Given this list of marker genes LAPTM5, GRIPAP1, LCK, PDE1B, MARCKSL1, SPAG9 (sperm associated antigen 9), AMZ1, HLA-DRA, REL, ATP6V0A1, BEX3, AHR, PEA15, RCHY1, CD72, GAA, TPRA1, EGFL6, MAP2K3, CD84, RPS6KA2, ORAI1, IGF2R, ZFP36L2, CD86 (CD86 molecule), PLEK, MIR22HG, VCL, PCYT1A, DLK1, TPD52 (tumor protein D52), FNBP1, SSBP4, CCR6, ITPRID2, TOB2, FOSL2, PFKP, UBE2D1, RASA2, PLEKHF2, OXCT1, TCEAL9, EPHA8 (EPH receptor A8), VEGFB, CORO7, EMILIN2, LAT2, MYO1E, SLC9B2, SLC38A1, SPRY1, ERF, DGKD, SLC17A9, IL2RG, FABP5, IL7R, SMAD3, MIDEAS, SARS1, PMP22, SLCO4A1, NFATC1, PER1, TXNDC16, PRXL2A (NCBI Gene Id 84293), RBPJ (NCBI Gene Id 51580), GNG4, AK7, IL33, GFI1, PTGER4, CHRND, PTPN22, LONRF3, RGS2, MAST3, CD53, SPP1, TUBB2A, UAP1L1, LYL1, LBH, SH3BGRL, CHST11, RAB3GAP2, CCNG2, GATA5, MALT1, GPR183, UBP1, CBX7, IL6ST, DUSP4, STARD4, C11orf96, NRGN, OVOL2, TNFRSF13C, RASD1, DMTF1, DDIT4, RILPL2, SLC17A5, CBLC, TRIB2 (tribbles pseudokinase 2), RETREG1, LZTFL1, RHOF, EPHX1 (epoxide hydrolase 1), M6PR, WIPF1, ATP6V0D1, CR2 (NCBI Gene Id 1380), IL1R2, XCL1, OSBPL3, EGR2, RENBP, NSMF (NCBI Gene Id 349336), VPREB3, B3GNT5, ALCAM, SACS, S1PR3, HLA-DRB1, SNAI3, CXCR3, CSTB, IRS2 (NCBI Gene Id 90066), IER2, RGS1, RMND5B, BCL9, CD27, MYO1C, PDE2A, MANEA, DTX1, MYO1B, TMEM40, HIVEP3, TGFB1, KRTCAP3, IRF2BPL, TPST2 (tyrosylprotein sulfotransferase 2), XBP1, RGS16, MMD, EGR1, NCS1, NR4A2, FCMR, SEMA4D, LAT, USP2, ZSWIM4, FOSB, NAB1, SEPTIN7, TSC22D1, NR4A3, KLF10, LITAF, RGS13, CST7, CD74, CHKA, TMC6, KLHL18, SRPK2, DCAF12, CABLES1, CTSA, TIPARP, PRKCA, TUBA3C, WDR81, INPP5D, EYA3, HIC1, TUBB2B, CD28, TMEM51, LRRC8D, CYBA, DMXL1, NAB2, PLBD1, EGR3, AP1M2, ITGAV, C18orf54, BEX1, FOXN2, IDE, SH2D2A, TMEM74B, FXYD5, here is a description of the gene set: CD4 T follicular helper (Tfh) cells provide the required signals to B cells for germinal center reactions that are necessary for longlived antibody responses. However, it remains unclear whether there are CD4+ memory T cells committed to the Tfh lineage after antigen clearance. Using adoptive transfer of antigen-specific memory CD4+ subpopulations (based on CXCR5 and Ly6c expression)in the LCMV infection model, we found that there are distinct memory CD4+ T cell populations with commitment to the Tfh and Th1 lineages. Our conclusions are based on gene expression profiles, epigenetic studies and phenotypic and functional analysis. The gene expression profiles of virus-specific CD4 T cell subets at effector and memory stages is presented here. Genes up-regulated in Th1 CD4 SMARTA T cells: effector during acute infection of LCMV versus memory. from publication Hale JS, Youngblood B, Latner DR, Mohammed AU, Ye L, Akondy RS, Wu T, Iyer SS, Ahmed R (PMID 23583644) Human Gene Set: GSE43863_DAY6_EFF_VS_DAY150_MEM_TH1_CD4_TCELL_UP studied in species Homo sapiens